Given this list of marker genes RPGR, GLCCI1, CSNK2A1, WAPL, ACTC1, CDYL, TSC22D2, FAM169A, PTBP3, COX16, HIPK1, ANKRD20A3P, PPIL1, NELL2, KLHL13, DCN, SLC35G2, MTF1, LCORL, CRISP1, TTI2, KLHL15, CENPJ, STRN, C14orf39, THOC2, FEM1B, PPM1E, ERCC4, FLRT2, ELL2, NUFIP2, SHTN1, MECP2, ZDHHC17, HORMAD1, PRPF18, CYCS, CHD6 (chromodomain helicase DNA binding protein 6), NPLOC4, ACSL3, TM4SF18, VPS13B, XRN2, TRPM3, FAM110B (NCBI Gene Id 90362), DDX3Y, EPHA7, ELAVL2, SPTLC1 (serine palmitoyltransferase long chain base subunit 1), HNRNPH2, DTNA, ETV1, C11orf97, RPL36A-HNRNPH2, SHOC2, YTHDC1, ELOC, KLHL28, RABGAP1, LACC1 (NCBI Gene Id 144811), MRTFB, CDK8, C5orf22, AP4E1, BNC2, JUND, ZIC5, LPAR4, GABRA6, ARID1A, ARGLU1 (NCBI Gene Id 55082), CAPN6, LPCAT3, DCP2, PDIA3, MEX3C, TENT5D (NCBI Gene Id 169966), CCNT2, MON2, CCNJ, AKTIP, FYTTD1, QSOX2, TMEM196, CLIC1, ARL3, CCDC34, DDX6, CTAGE1, ESF1, SYNJ2BP-COX16 (SYNJ2BP-COX16 readthrough), THSD7A, ITPRIPL2, PSG6, NCAM1, PLD5, DDHD2, CCND2, NRP1, LITAF, ZNF264, KCND2 (NCBI Gene Id 3751), FAIM, BTF3L4 (NCBI Gene Id 91408), LRP4, CFL2, RS1, ZDHHC21, HS3ST3A1, TGFBR3, SATB2, TPD52, PGD (phosphogluconate dehydrogenase), CHP1, PTPN21, DLG1, EIF4E, SLITRK1, ANKRD13C, MTCP1, ASXL3, PKD2L2, DR1, WASHC5, MIB1, SPIRE1, ATP8A1, ZNF827, MINDY2 (NCBI Gene Id 54629), RASSF8, ZNF551, CTBP2, MBLAC2, MAPK9, SEPTIN10, PREPL, YWHAE, here is a description of the gene set: from publication Chen Y, Wang X (PMID 31504780) Genes predicted to be targets of miRBase v22 microRNA hsa-miR-4724-5p in miRDB v6.0 with MirTarget v4 prediction scores > 80 (high confidence targets). studied in species Homo sapiens Human Gene Set: MIR4724_5P